The following is a description of a gene set: Human Gene Set: GOCC_RESPIRATORY_CHAIN_COMPLEX_III A protein complex that transfers electrons from ubiquinol to cytochrome c and translocates two protons across a membrane. The complex contains a core structure of three catalytic subunits: cytochrome b, the Rieske iron sulfur protein (ISP), and cytochrome c1, which are arranged in an integral membrane-bound dimeric complex; additional subunits are present, and vary among different species. species: Homo sapiens, and this is the list of marker genes: MT-CYB, UQCRFS1, BCS1L, UQCRB, UQCRH, UQCRQ, UQCR10, UQCRHL, CYC1, UQCRC2, UQCR11, UQCRFS1P1, UQCRC1